Given this list of marker genes NR4A2, ADGRA2, OLFM3, MEIS1, OAS3, TPSAB1 (tryptase alpha/beta 1), HOXA9, FLT3, IFIT3, OSBPL6, PPP1R14A, LAMP5, CNKSR3, ZNF503, ABCB1, DHRS3, LY6E, TSC22D1 (NCBI Gene Id 8848), CAVIN2, CTSG, SLC9A3, ATP7B, LGALS3BP, IGFBP4, IFI27, THBS1, F2R, SLC12A8, RSAD2, TSLP, GPR18, PLD4, EIF2AK2, TMT1B, ANGPT1, STAT1, HIC1, DNAJC6, HBB, BDNF, IFI6, JCHAIN, SPINK2, FHL2, CALB1, REXO2 (RNA exonuclease 2), TAL1, MX2, ALDH1A1, OAS1, RNF213, NOG, RHAG, NAP1L5, CCDC71L, HOXB-AS3, CRISP3, CDH1, XAF1 (XIAP associated factor 1), IL22RA2, GBP1, DENND6B, IFIT2, LINC00996, FOXC1, EPSTI1, MEF2C, ENPP2, AUTS2 (activator of transcription and developmental regulator AUTS2), MYH10, DEFB1, HOPX, RIGI, OAS2, SLC27A6, HOXA7, IFITM1, ADCYAP1, HOXB3, GZMB, LXN, IGLL1, CLEC2B, USP18, NMU, DDX60, RBPMS, IFI44L, TGM5, IFIH1, GCH1, MYCT1, GJA1, IRF7, MX1, MAP7, KLF1, IFIT1, RBM11, MTSS1, HERC5, RPS6KA5, LTBP3 (NCBI Gene Id 4054), DLC1, TNFAIP6, RXFP1, ADRB1, REN, NEGR1, RHOBTB1, SMIM24, HERC6, ASB2, TUBB2A, KRT18, HBD, SDSL, MYCN, APOC1, CHST2, PRKAR2B, RAB27B, SPTA1, ISG15, ISYNA1, TYRP1, GDF15, HBBP1, IFI44, TTC28, MECOM, PCDH9, SLC40A1, PALLD, IRX3, HS3ST3B1, C3orf80, AMMECR1, PTGS2, FAT1, SLC6A13, CELA2B, CMBL, FGF18, HOXA3, HOXA5, SOX4, CCR7, SPOCK1, MIR155HG, GAD1, GDPD1 (NCBI Gene Id 359824), IFIT5, PRSS23, DDIT4, IDO1, here is a description of the gene set: species: Homo sapiens Human Gene Set: TAKEDA_TARGETS_OF_NUP98_HOXA9_FUSION_8D_UP from publication Takeda A, Goolsby C, Yaseen NR (PMID 16818636) NUP98-HOXA9, the chimeric protein resulting from the t(7;11)(p15;p15) chromosomal translocation, is a prototype of several NUP98 fusions that occur in myelodysplastic syndromes and acute myeloid leukemia. We examined its effect on differentiation, proliferation, and gene expression in primary human CD34+ hematopoietic cells. Colony-forming cell (CFC) assays in semisolid medium combined with morphologic examination and flow cytometric immunophenotyping revealed that NUP98-HOXA9 increased the numbers of erythroid precursors and impaired both myeloid and erythroid differentiation. In continuous liquid culture, cells transduced with NUP98-HOXA9 exhibited a biphasic growth curve with initial growth inhibition followed by enhanced long-term proliferation, suggesting an increase in the numbers of primitive self-renewing cells. This was confirmed by a dramatic increase in the numbers of long-term culture-initiating cells, the most primitive hematopoietic cells detectable in vitro. To understand the molecular mechanisms underlying the effects of NUP98-HOXA9 on hematopoietic cell proliferation and differentiation, oligonucleotide microarray analysis was done at several time points over 16 days, starting at 6 hours posttransduction. The early growth suppression was preceded by up-regulation of IFNbeta1 and accompanied by marked up-regulation of IFN-induced genes, peaking at 3 days posttransduction. In contrast, oncogenes such as homeobox transcription factors, FLT3, KIT, and WT1 peaked at 8 days or beyond, coinciding with increased proliferation. In addition, several putative tumor suppressors and genes associated with hematopoietic differentiation were repressed at later time points. These findings provide a comprehensive picture of the changes in proliferation, differentiation, and global gene expression that underlie the leukemic transformation of human hematopoietic cells by NUP98-HOXA9. Genes up-regulated in CD34+ hematopoetic cells by expression of NUP98-HOXA9 fusion off a retroviral vector at 8 days after transduction.